The following is a description of a gene set: studied in species Homo sapiens In this study gene expression of human blood classical monocytes (CD14++CD16-), CD16 positive monocytes (consisting of non-classical CD14+16++ and intermediate CD14++CD16+ monocytes) and CD1c+ CD19- dendritic cells from healthy subjects were investigated. Genes up-regulated in monocytes: CD16- versus CD16+. from publication Frankenberger M, Hofer TP, Marei A, Dayyani F, Schewe S, Strasser C, Aldraihim A, Stanzel F, Lang R, Hoffmann R, Prazeres da Costa O, Buch T, Ziegler-Heitbrock L (PMID 22531920) Human Gene Set: GSE34515_CD16_NEG_VS_POS_MONOCYTE_UP, and this is the list of marker genes: IGSF3, MT1E, NT5DC3, PIK3R3, PCLO, SSUH2 (NCBI Gene Id 51066), ZBP1, ATIC, SLC16A1, LIPN, FAM181A, SLC7A2, CACNA1F, IL6ST, FAAP24, NAGPA, SPTLC3, CAVIN1, CUTA, LDLR, RETSAT, NSDHL, TMT1A (NCBI Gene Id 25840), ACO2, TMEM239, SGPP2, KLF4, ZNF585A, SMIM5, ATG9B, RASGRP1, INPP5A, ELOVL1, ATP5F1B, F10, JAK2, NSG2, PSMB10, CTSZ, SST, ISYNA1, UQCRQ, IL17D, GLRX, GAMT, MCF2L, HLA-DMA, SCN1A, RAB10, CPA6, TRAF5 (NCBI Gene Id 7188), CLIC4, DOLK, ARL15 (ADP ribosylation factor like GTPase 15), WDR31, HEBP2, OCSTAMP (NCBI Gene Id 440764), KCNK3, MCRIP2, DDX56, FUOM, MPZL3, CD300LD, ABLIM1, SMAP2, GMPR (NCBI Gene Id 2766), ADAMTSL2, P2RY1, PRKCD, RAB1B, AZIN2, CABP7, COX8A, HHAT, PRPS1, CD44, TNFRSF11B, AGPAT3, IFI30, IER5L, DZIP3, DNAJB11 (DnaJ heat shock protein family (Hsp40) member B11), RAB3IL1, MIR99AHG, RRP9, KLF9, OLFM1, SLC52A2, IER3, AUH, CLUH, ANKH, PLA2G5, FGD6 (NCBI Gene Id 55785), MEOX1, TUBA3C, NKD1, MICAL2, MED13L, AMBP, ACACB, OSTC, SPATA21, SLC48A1, PKP2, SLC30A4, FDPS, FASN, CCNE1, CASP6, SSBP4, TNNI3K, FN1, NFIL3, MAN1A1, ACY1, COX6C, SLC35A4, IFRD2, ITGAX, NAAA, RRP8, CD40, DUSP4, UQCR10, SSR4 (signal sequence receptor subunit 4), ZSWIM2, HLA-DOA, C16orf86, OXCT1, FADS3 (NCBI Gene Id 3995), RECQL5, TRIB1, KGD4, PTPRN, CD274, SIGMAR1, SPINK2, TFAP2C, SLC27A3, ECSIT, FMC1, DOK2, COLCA1, TMEM268, MPI, IL24, HIBADH, CAPN10, TBRG4, PTPRZ1, EYA2, TMX2, MVD, ATP5PO, COX6A2, BZW2, ALDH1B1 (NCBI Gene Id 219), ATP6V0A1 (NCBI Gene Id 535), FAM43B, SHOX2, IGF1, FLRT2, C16orf89, PTGS1, GULP1, SEPTIN9, PFKP, RIPK2, SLC15A3, NDUFA3, RP1L1, IRF4, TUFM, ZNF703 (NCBI Gene Id 80139), WDR83OS, SDHD, FKBP5, FAM20C, CHCHD10, HIGD1C (HIG1 hypoxia inducible domain family member 1C), CLEC10A, CCL24, PYCARD (NCBI Gene Id 29108), MRPL27, PPP1R14B, UQCRC1, DUT, KCNK6, CD52, SLC25A6 (solute carrier family 25 member 6), NUP54, APOH, COPS7B, PTGES2, EAF2 (NCBI Gene Id 55840), ATP5PF, SLC1A5, FCHSD2, NDRG2